The following is a description of a gene set: from publication Schaefer CF, Anthony K, Krupa S, Buchoff J, Day M, Hannay T, Buetow KH (PMID 18832364) Human Gene Set: PID_RHODOPSIN_PATHWAY Visual signal transduction: Rods species: Homo sapiens, and this is the list of marker genes: GUCA1A (guanylate cyclase activator 1A), SAG, RDH12, CNGA1, RGS9, PDE6G, GUCA1B, GNB1, RHO, GNB5, GNGT1, PDE6B, PDE6A, RPE65, SLC24A1, GNAT1, GUCA1C, LRAT, GRK1, GUCY2D, RDH5, GUCY2F, RGS9BP